The following is a description of a gene set: Any process that stops, prevents, or reduces the frequency, rate or extent of DNA recombination. Human Gene Set: GOBP_NEGATIVE_REGULATION_OF_DNA_RECOMBINATION species: Homo sapiens, and this is the list of marker genes: TP53BP1, PARPBP, KMT5A, HELB, ABL1, PLK1, H1-9P, SMCHD1, H1-0, SHLD3, H1-2, H1-8, BLM, MAGEF1, MSH3, BCL6, SHLD2, KAT5, H1-10, RIF1, RADX, TERF2, C1QBP, NDFIP1, H1-6, KLHL15, SHLD1, FBH1, MLH1, POLQ, MSH2, RECQL5, CGAS, ZSCAN4, MAD2L2, H1-1, RTEL1, FOXP3, UBQLN4, H1-3 (H1.3 linker histone, cluster member), TERF2IP, ANKLE1, H1-5, H1-7, FANCB, SENP3, MSH6, RMI2, H1-4, PARP3, CSNK2A1